The following is a description of a gene set: Determining the genetic basis of cancer requires comprehensive analyses of large collections of histopathologically well-classified primary tumours. Here we report the results of a collaborative study to discover somatic mutations in 188 human lung adenocarcinomas. DNA sequencing of genes with known or potential relationships to cancer revealed more than 1,000 somatic mutations across the samples. Our analysis identified genes that are mutated at significantly high frequencies and thus are probably involved in carcinogenesis. The frequently mutated genes include tyrosine kinases, among them the EGFR homologue ERBB4; multiple ephrin receptor genes, notably EPHA3; vascular endothelial growth factor receptor KDR; and NTRK genes. These data provide evidence of somatic mutations in primary lung adenocarcinoma for several tumour suppressor genes involved in other cancers--including NF1, APC, RB1 and ATM--and for sequence changes in PTPRD as well as the frequently deleted gene LRP1B. The observed mutational profiles correlate with clinical features, smoking status and DNA repair defects. These results are reinforced by data integration including single nucleotide polymorphism array and gene expression array. Our findings shed further light on several important signalling pathways involved in lung adenocarcinoma, and suggest new molecular targets for treatment. The lung adenocarcinoma TSP (tumor sequencing project) genes that were found significantly mutated by at least one method. studied in species Homo sapiens Human Gene Set: DING_LUNG_CANCER_MUTATED_SIGNIFICANTLY from publication Ding L, Getz G, Wheeler DA, Mardis ER, McLellan MD, Cibulskis K, Sougnez C, Greulich H, Muzny DM, Morgan MB, Fulton L, Fulton RS, Zhang Q, Wendl MC, Lawrence MS, Larson DE, Chen K, Dooling DJ, Sabo A, Hawes AC, Shen H, Jhangiani SN, Lewis LR, Hall O, Zhu Y, Mathew T, Ren Y, Yao J, Scherer SE, Clerc K, Metcalf GA, Ng B, Milosavljevic A, Gonzalez-Garay ML, Osborne JR, Meyer R, Shi X, Tang Y, Koboldt DC, Lin L, Abbott R, Miner TL, Pohl C, Fewell G, Haipek C, Schmidt H, Dunford-Shore BH, Kraja A, Crosby SD, Sawyer CS, Vickery T, Sander S, Robinson J, Winckler W, Baldwin J, Chirieac LR, Dutt A, Fennell T, Hanna M, Johnson BE, Onofrio RC, Thomas RK, Tonon G, Weir BA, Zhao X, Ziaugra L, Zody MC, Giordano T, Orringer MB, Roth JA, Spitz MR, Wistuba II, Ozenberger B, Good PJ, Chang AC, Beer DG, Watson MA, Ladanyi M, Broderick S, Yoshizawa A, Travis WD, Pao W, Province MA, Weinstock GM, Varmus HE, Gabriel SB, Lander ES, Gibbs RA, Meyerson M, Wilson RK (PMID 18948947), and this is the list of marker genes: CDKN2A, NRAS, EPHA3, EGFR, ZMYND10, NTRK1, ERBB4, TP53 (NCBI Gene Id 7157), PDGFRA, LRP1B, PAK3, KRAS, APC, NF1, ATM, NTRK3, EPHA5, PTPRD, LTK, SLC38A3, STK11, KDR, INHBA, FGFR4, RB1, GNAS